The following is a description of a gene set: Human Gene Set: REACTOME_NA_CL_DEPENDENT_NEUROTRANSMITTER_TRANSPORTERS studied in species Homo sapiens Na+/Cl- dependent neurotransmitter transporters, and this is the list of marker genes: SLC6A12, SLC6A20, SLC6A18, SLC6A19, SLC6A7, SLC6A1, SLC6A2, SLC6A5, SLC6A9, SLC22A1, SLC6A15, SLC6A14, SLC22A2, SLC6A11, SLC6A3, SLC6A6, SLC18A2, SLC18A1, SLC6A13